The following is a description of a gene set: Human Gene Set: GOMF_MRNA_3_UTR_BINDING Binding to a 3' untranslated region of an mRNA molecule. studied in species Homo sapiens, and this is the list of marker genes: MIR9-1, MIR34B, MIR23A, ANGEL1, MIR515-1, APOBEC1, MIR675, RBM4, MIR93, MIR206, TAF15, MIR183, DHX36, DAZAP1, MIR219A1, MIR100, MIR26A1, HNRNPA1L3, RC3H1, DAZ1, PABPC1L2B, RBPMS, HNRNPU, MIR212, IGF2BP1, PABPC1, MIR214, MIR338, MIR143, MIR98, EXOSC7, ELAVL3, BOLL, DAZ3, DDX5, MIR296 (microRNA 296), MIR29A, MIR520D, MIR181B1, MIR19A, MIR29B1, MIR144, MIR208B (microRNA 208b), RBMS1, MIR21, PARN, MIR486-1, MIR323A, TIA1, MIR1-1, RBM38, MIR92B, DAZ2, GEMIN5, AGO2, ELAVL1, RPL41, MIR199A1, MIR508, MIR96, MIR573, MIRLET7I, EXOSC4, MIR346, MIR130B, MIR10A, MIR139, MIR543, MIR3619, MIR153-1 (NCBI Gene Id 406944), MIR101-1, TARDBP, IGF2BP2, MIR1298, MIR548D1, MIR708, ZAR1L, ELAVL4, MIR1246, MIR384, MIR133A1, RBM44, MIR105-1, MIR193B, MIR208A (NCBI Gene Id 406990), NOVA1, MIR379, MIR3661, NICOL1, MIR151A, MIR20A, MIR608, MIR223 (NCBI Gene Id 407008), HNRNPA1L2, MIR138-1, ZC3H12A, MIR130A, MIR106A (NCBI Gene Id 406899), MIR137, LARP4B, HNRNPA3, MIR127, CPEB4, RNF20, SECISBP2L, YBX3, MIR551A, MIR125A, MIR152, RSL1D1, LARP4, QKI, MIR193A, MIR134, UTP23, RPL5, MIR361, ILF3, FUS, CCT5, MIR30A (NCBI Gene Id 407029), NHP2, RBM47, MIR92A1, CELF1, ZAR1, MIR33A, MIR506 (microRNA 506), MIR339, MIR30D, MEX3D, SECISBP2, MIR133B, MIR328, MIR483, MIR140, MIR6086, HNRNPA2B1 (NCBI Gene Id 3181), MIR613, MIR146A, MIR204, MIR129-1, MIR24-1, MIR28, MIR186, MIR17, MIR200B, HNRNPA1, DND1, TP53, RNF40, MIR1271, CSDC2, IGF2BP3, MIR34A, PABPC4, ZFP36, RBMS2, ZFP36L2, FMR1, MIR128-1, MIR455, ZFP36L1, CIRBP, MIR34C, ELAVL2, MIR495, MIR335, MIR374A, MIR99B, RNPS1, MIR451A, MIR126, MIR27B, MIR195, ANGEL2, MIR374B, ZNF385A, MIR185 (microRNA 185), MIR302C, RPS7, MIR519D, MIR106B, CRYZ, EXOSC9, MIR16-1, DAZ4, MIR20B, ARID5A, HNRNPD, MIR3173, NUDT21, MIR326, MIR873 (NCBI Gene Id 100126316), MIR15B, MIR192, MIR493, RBMS3, MIR142, PABPC1L, MIR141, MIR135B, MIR1908, EXOSC8 (NCBI Gene Id 11340), KHSRP, LARP1, MIR769, MIR29C, MIR448, FXR2, MIR145, MIR125B1, SERBP1, CPEB2, TUT1, MIR224, PABPC1L2A, MIR665, ZC3H14, CELF2, MIR205, MIR429, MIR497, MIR498, MIR200C, LRPPRC, TIAL1, CARHSP1 (calcium regulated heat stable protein 1), PUM1, DAZL, MIR27A, AUH, MIR424, PCBP4, MIR491, MIR520C (NCBI Gene Id 574476), CPEB3, MIR298, MIR181A2, MIR501, CPEB1 (cytoplasmic polyadenylation element binding protein 1), PABPC3, MIR885, MIR15A, MIR31, MIR650, HNRNPA0, MIR499A (NCBI Gene Id 574501), MIR644A, MIR10B, HNRNPC (heterogeneous nuclear ribonucleoprotein C), MIR155, PABPC5, FXR1, RBM24, PABPC4L, MIR33B, MIR148B, CPSF1, MIR103A1, MIR147A, PUM2, MIR210